The following is a description of a gene set: Mouse Gene Set: GOBP_INNATE_IMMUNE_RESPONSE_ACTIVATING_CELL_SURFACE_RECEPTOR_SIGNALING_PATHWAY species: Mus musculus The series of molecular signals initiated by a ligand binding to a cell surface receptor that leads to the activation of an innate immune response., and this is the list of marker genes: Irak1, Tnip2, Nr1d1, Bpifb1, Sqstm1 (sequestosome 1), Oas1e, Klrd1, Tlr1, Wdfy1, Nod2, Rab11fip2, Lyn, Irak2, Map3k7, Oas1h, F2rl1, Klri1, Scimp, Tlr5, Clec4n, Mbl2 (mannose-binding lectin (protein C) 2), Tril, Trem2, Oas1a, Irf3, Ptpn22, Pja2, Plcg2, Ltf, S100a14, Tlr6, Appl2, Tmem126a, Oas1b, Ripk2, Clec7a, Tnip3, Mfhas1, Appl1, Ticam1, Letmd1, Klri2 (killer cell lectin-like receptor family I member 2, NCBI Gene Id 320407), Nfkbia, Ticam2, Rab7b, Ecsit, Tyrobp, Oas1f, Oas1g, Peli1, Dab2ip, Klrc2, Ninj1, Klrc1, Fcna, Lbp, Ifi35, Pik3r1, Tirap, Chuk, Tbk1, Traf3, Trim32, Tlr4, Klre1, Lrrfip2, Nmi, Tlr2, Tnfaip3, Cd14, Fcnb, Syk, Nr1h3, Ffar2, Pik3ap1, Naglu, Klrc3, Klrk1, Arf6, Rela, Oas1d, Prkce, Tax1bp1, Oas1c, Znrf1, Hmgb1, Cyba, Myd88, Ly96, Acod1 (aconitate decarboxylase 1), Traf6